Given this list of marker genes COQ8A, IGLV4-60, BTNL8, TDRD12 (NCBI Gene Id 91646), AGRP, ITK, TGFB2, ZNF529, ATG9A, PCCA, SIN3B (NCBI Gene Id 23309), PARG, MISP, LGALS14, GUCY1A1, MYH3, FCGBP, ARHGEF6, GATA3, SCNN1B, CTDP1, ENSG00000274253, FLT1, NMRK2, RARB, SLC25A42, WASF1, MYDGF, GTPBP4 (NCBI Gene Id 23560), SYT12, MT4, COL9A1, PCOTH, F2RL2, AGPAT5, IFNA2, GNL3LP1, EMCN, FAM13B, GATM, LRRTM2, ZDHHC8BP, P2RY14, GIN1, AQP9, RBM28, C10orf88, THAP3, SHC3, FUT3, ELANE, ZNF384, AIMP2, FOXO1, RABGEF1, C1QB, USP27X, HAND2-AS1, CCDC70, NPC1L1, CFAP74, TXNDC15, GNAT1, GRIP2, HMCES, IL21, HBEGF, F10, NRIP3 (NCBI Gene Id 56675), TRIM38, MMP10, GP1BA, BRF2, IFNA14, H2AP, TLX1, FAP, CNTN2, POM121L9P, LILRB5, SLC34A2, LAMC3, SPG11, COL5A3, CYRIA, SSR3, NDUFAF1, TGOLN2, PRKCE, MIA, STUM, ZMYM2, PPIP5K1, DMWD, HDAC4, ANXA2, CD40, STC2, CSH2, PIP5K1A, RNF10, TACC2, TSBP1, HMGCS2, SEMA3D, FNDC4, LXN, SCN4A, DAGLA, IFIT5, HIBCH, H4C7, CRLF2, SLC6A16, B3GALT1, NEUROG2, NIPAL2, POGZ, FOXJ3, GPATCH1, SFXN3, RARS2, ENSG00000284948, RNF103 (ring finger protein 103), MYO16, RAVER2, SOX18, AGO3, HIVEP2, TMEM14A, CDK17, MCF2L2, MAEA, GNG7, TLR7, TRIT1, ADAMTS6, PFDN1, KCNA4, TRHDE, PGM1, SEC23B, RETREG1, SLC35E2B, SCAMP5, GALNT14, KPNA1, IL21R, CACNG2, CCL24, WLS, P3H2, STK38, EN2, OXT, DIDO1, NKX2-5, BICRA, PTGER1 (prostaglandin E receptor 1), RBM8A, RIMS1, DDX17, FMO5, COL4A6, PGAP4, GNRHR, MSL1, CA14, MOCS1, EDIL3, CD1B, BARX1, HNF1B, EEF1A2, CPB1, POU5F1P4, RTN2, DUOX2, ZNF14, PDE6C, GABRA3, TLL1, SARM1, HHAT, UBE3B, GRM3, CCDC181, PORCN, ERG, SHARPIN, SLC36A1, ADGRL3, TCF7L1, EFNA2, ETV4, TATDN2, here is a description of the gene set: Human Gene Set: GSE37301_LYMPHOID_PRIMED_MPP_VS_CD4_TCELL_UP Genes up-regulated in lymphoid primed multipotent progenitors versus CD4 T cells. species: Homo sapiens from publication Ramirez K, Chandler KJ, Spaulding C, Zandi S, Sigvardsson M, Graves BJ, Kee BL (PMID 22608498) Expression profiling of Rag2-deficient Ets1++ and Rag2-deficient Ets1-- mature NK cells and WT bone marrow progenitors, WT T cells, and WT Pro B cells